Given this list of marker genes Hdac1, Smurf2, Smad1, Ski, Sptbn1, Tjp1, Ctnnb1, Klf10, Ube2d3, Fkbp1a, Skil, Ppm1a, Ifngr2, Ppp1r15a, Nog, Cdk9, Slc20a1, Cdh1, Apc, Fnta, Smad7, Trim33, Map3k7, Bmpr2, Smad3, Ncor2, Smurf1, Eng, Bmpr1a, Ppp1ca, Pmepa1, Id3, Rhoa, Id2, Furin, Junb, Xiap, Ltbp2, Acvr1, Smad6, Tgfbr1, Bcar3, Tgif1, Thbs1, Tgfb1, Wwtr1, Arid4b, Cdkn1c (NCBI Gene Id 12577), Id1, Serpine1, Hipk2, Bmp2, Rab31, here is a description of the gene set: Mouse genes annotated to HALLMARK_TGF_BETA_SIGNALING based on orthology mappings provided by the Alliance Genome Consortium species: Mus musculus from publication Howe DG, Blake JA, Bradford YM, Bult CJ, Calvi BR, Engel SR, Kadin JA, Kaufman TC, Kishore R, Laulederkind SJF, Lewis SE, Moxon SAT, Richardson JE, Smith C (PMID 30224793) Mouse Gene Set: HALLMARK_TGF_BETA_SIGNALING